Given this list of marker genes CDK5, RANGAP1, BARD1, SP100, PARK7, HDAC3, TXN, FAM76B, here is a description of the gene set: species: Homo sapiens Human Gene Set: GOBP_NEGATIVE_REGULATION_OF_PROTEIN_EXPORT_FROM_NUCLEUS Any process that stops, prevents, or reduces the frequency, rate or extent of the directed movement of proteins from the nucleus into the cytoplasm.